The following is a description of a gene set: The multiplication or reproduction of fat cells by cell division, resulting in the expansion of their population. A fat cell is an animal connective tissue cell specialized for the synthesis and storage of fat. Human Gene Set: GOBP_FAT_CELL_PROLIFERATION species: Homo sapiens, and this is the list of marker genes: PPARD, COL6A1, LIPA, TREM2, PER2, PID1, SLC2A4, TFDP1, E2F1, FGF10, DIO3, VSTM2A, E2F3, FTO, SQSTM1